The following is a description of a gene set: species: Mus musculus Mouse Gene Set: chr13C1, and this is the list of marker genes: 4933416O17Rik, 2210408I21Rik, Arsk, Gpr150, Slc6a19, Hnrnpa1l2-ps, Srd5a1 (NCBI Gene Id 78925), Adamts16, Slc9a3, Slc6a3, Ccdc127, Gm8227, Gm8278, Gm15528, Gm31219, Irx4, Tert, Gm46387, Rpl31-ps2, Fam81b, AU017674, Arb2a, Gm3926, Gm47655, Mrpl36, Gm10263, Irx1, Trip13, Pdcd6, Mir682, Ndufs6, Sdha, Cep72, Gm15912, Gm5626, Gm23012, Slc6a18, Erap1, Tppp, Gm46430, Gm26088, Gm4057, D730050B12Rik, Gm6311, Gm31946, Pou5f2, Gm8062, Gm38604, Mir692-3, 1700100L14Rik, Gm9634, Gm3963, 1700037F03Rik, Skic3, E430024I08Rik, C130051F05Rik, Gm8288, Gm38191, Slc6a19os, Gm20288, Rfesd, 4930520P13Rik, Gm26018, Mir466f-4, Gm17872, D030007L05Rik, Zfp72, Gm16125, Gm36607, Med10, Ice1, 1700112M02Rik, Slf1, Gm36529, Rhobtb3, Gm40999, Ell2, Gm6317, Zfp825, Gm36377, 1700084F23Rik, Gm6263, Gm41002, Cast, Clptm1l, 3110006O06Rik, Gm6296 (predicted gene 6296), 4930547H16Rik, Gm23319, Lrrc14b, Gm4149, Zdhhc11, Gm24163, Gm4165, Rpl9-ps4, Atp5c1-ps, Ahrr, Gm4052, Eprn, Brd9, 8030423J24Rik, Gm23127, Glrx, Spata9 (spermatogenesis associated 9), Gm19095, Nr2f1, Mctp1, Gm21959, Gm35618, Gm36426, Ube2ql1, Pcsk1, Gm18990, Slc12a7, Nkd2, Ftl1-ps1, Lpcat1, Gm15740, Gm5042, Gm8185, Gm20554, Gm29844, Irx2, Gm3772, Exoc3, Gm18313, Gm10126 (predicted gene 10126), A830082K12Rik